Given this list of marker genes MTHFS, ACOT4, GAD2, GLUD2, GOT2 (NCBI Gene Id 2806), PM20D2, ALDH1L1, ALDH1L2, DDO, GOT1, AASDHPPT, ACSF3, ADHFE1, ACOT8, GLUD1, GAD1, GLUL (glutamate-ammonia ligase), QPRT, here is a description of the gene set: Human Gene Set: GOBP_DICARBOXYLIC_ACID_CATABOLIC_PROCESS The chemical reactions and pathways resulting in the breakdown of dicarboxylic acids, any organic acid containing two carboxyl (-COOH) groups. studied in species Homo sapiens